Given this list of marker genes APC, ATP6AP1 (NCBI Gene Id 537), PNPO, FGF23, RPL5, RPS7, UBE2T, DHFR, FN1 (NCBI Gene Id 2335), TPI1, MAD2L2, CDIN1 (NCBI Gene Id 84529), XRCC2, SCARB2, PIEZO1, SF3B1, NAA10, LARS1, MTHFD1, AGGF1, SUCLA2, RPS15A (NCBI Gene Id 6210), HBA1, RPL31, CYP2R1, CP, OPA1, PSMC1, FANCF, SRSF2, FANCI, ABCD4, RACGAP1, CD55, DNAJC19, TINF2, CLPX, RIPK1 (receptor interacting serine/threonine kinase 1), HPRT1 (NCBI Gene Id 3251, hypoxanthine phosphoribosyltransferase 1), DNAJC21, SLC12A3, UQCRFS1, ISCU, OSTM1 (osteoclastogenesis associated transmembrane protein 1), ASXL1, RAC2, SLC19A1, UMPS, RPS26, TAFAZZIN, LCAT, ABCD3, LARS2, CUBN, SLC19A2, EFL1, COL2A1, SFXN4, RHAG, HBA2, RPS14, BRIP1, COX10, IRX5, TEK, BRCA2, ALDOA, FAS, TET2, TRNT1, DNM1L, CBLIF, PHGDH, LPIN2, RFWD3, TREX1, CYP27B1, SLC35C1, RPS20, FOXP3, RPL9, RPS29, CLCNKB, HBG2, LMBRD1, MVK, FECH, ELF4, PRDX1, SLC46A1, RPS28, RPL27, PSTPIP1, KCNQ1, TF, SHPK, FANCB, SBDS, SLX4 (SLX4 structure-specific endonuclease subunit), C2orf69, FANCC, TOR1A, FANCM, ATRX, CDAN1, TKFC, KCNE1, RAD51 (RAD51 recombinase), FANCL, STEAP3, EIF2AK3, RAD51C, RPL26, TSR2, COL7A1, DIAPH1, RPS24, FANCD2, SLC25A21, UBA1, SLC37A4, ALG2, KCNN4, MTR, ZNF699, PSMB8, TMPRSS6, RHD, SLC25A38, TGFB1, FASLG, SMPD1, WFS1, RPL35, BCL11A, FDX2, STK11, RPS17, TCN2, KIF23, MMADHC, MMP1, HLA-DQB1, HK1, KARS1, GATA1, HBB, MTRR, SLC25A10, SEC23B, IREB2, KIT, ADA2, FTCD, CAT, RPL8, HSCB, PIK3CA, IL6ST, RPL35A, ABCB7, RPS27, YARS2, PLA2G4A, CASP10, MYD88, SLC4A1, SLC29A3, TBK1, COX4I2, KLF1, CARD10, RPS10, SRD5A3, FANCE, RPL11, RPL15, FARSA, PALB2, PUS1, FANCA, RMRP, SAMD9L, MMACHC, RPL18, HEATR3, HSPA9, WIPF1, ELMO2, FANCG, SLC30A7, RPS19, HBG1, GALNT2, BRCA1, RHCE, WAS, AMN, HBD, ERCC4, ALAS2, HLA-DQA1, here is a description of the gene set: Human Gene Set: HP_ANEMIA_OF_INADEQUATE_PRODUCTION A kind of anemia characterized by inadequate production of erythrocytes. studied in species Homo sapiens Anemia of inadequate production